Given this list of marker genes Lig3, Mpv17, Ssbp1, Stox1, Mtnap1, Atg7, Endog, Mettl4, here is a description of the gene set: Mouse Gene Set: GOBP_REGULATION_OF_MITOCHONDRIAL_DNA_METABOLIC_PROCESS studied in species Mus musculus Any process that modulates the frequency, rate or extent of mitochondrial DNA metabolic process.